Given this list of marker genes Arl4c, Ncoa2, Cxcl14, 1700072I22Rik, Vamp2, Igkv10-95, Frmd8, Chn1, Gm7969, Ccdc136, Emp1, Cyp2e1, Pex11a, Sult4a1 (sulfotransferase family 4A, member 1), AI504432 (NCBI Gene Id 99661), Fam110b, Laptm4b, Fbxw14 (NCBI Gene Id 99238), Pard6g, Prkce, Zxdb, Lrrtm4, Igdcc4, Itih5, Fam181b, Ftdc2, Def8, Smad7, Glb1l, Bcl2l11, Etv3, Ifih1, Ash1l, Pde4b, Zcchc7, Gm1965, Clps, Ccar1, Cpxm1, Baalc, Nsd3, Etv1, Syn2, Sv2a, Pdc, Msi2, Arhgap42, Jade1, Dnajb13, Foxb2, Kcnj6, Cers4 (NCBI Gene Id 67260), Gem, Wnt6, Ift81, Prkacb, Inppl1 (NCBI Gene Id 16332), Tspan6, Vps37a, Rbm28, Gnl1, Nkain3, Ifi44, Zmynd8, Tctn2, Pdf, Ctla2a, Vldlr, Egr1, Ptprk, Dusp5, Ntrk3, Slc25a30, Cyp2d22, S100a5, Nkx2-9, Col18a1, Esr1, Cpsf2, Zc2hc1a, Robo4, Lrrc49, Socs5, Mef2d, Misfa, Smarca2, Zbtb37 (NCBI Gene Id 240869), Klhl26, Plac8l1, Usp38, Nfkbia, Rbx1, Efna3, Gapdhs, Lpar4, Agxt, Arhgef28, Pck1, Rbbp6, Peak1, Palmd, Pygm, Myo10 (NCBI Gene Id 52514, myosin X), Nr4a1, Pkd2, Smc5, Prcd, Rps6ka3, Slc23a2, Emcn, Hyal1, Fundc2b, Zc3h12c, 1700001G11Rik, Hnrnpr, Cobll1, Jun, Rest, Sos1, Slit2, Cdip1, Polr2a, Marchf9, Fam168b, Cd164l2, Kcnk15, Nfatc2, Ptgr1, 1700108J01Rik, Trim61, Dydc1, Zbtb20, Ctnnal1, Tspan13, Mycbp2, Tcf25, Gata3, Slc41a1, Tbxa2r, Tgoln1, Slc35f1 (NCBI Gene Id 99729), Sema3d (sema domain, immunoglobulin domain (Ig), short basic domain, secreted, (semaphorin) 3D), Rasd1 (NCBI Gene Id 19416), Prkg1, Tcf4, Zdbf2, Camta1, Septin3, Scaf11, Nfkbie, Nrxn3, Siah2, Itga3, Hoxb2, Gatad2a, Paip1, 4930486L24Rik, Kif5a, Rilpl1, Iqgap2, Serpinb8, Ppp1r9a, Il36a, Sec14l3, Chrnb1, Wwc2, Nr4a2, Cdk14, Zrsr2, Dnmt3a, Lypd1, Mirlet7d, Arhgap32, Ddit4, Sema4c, Gm30230, Itga9, Usp34, Maff, Col4a1, Abcc12, Ccl19, Dnajc21, Ccdc185 (NCBI Gene Id 433386), Zfp40, Sash1, Chrna6, Srek1, Samd10, Trim9, Nfix, Pitpnc1, Tha1, Syt11, Slc16a5, Sgsm1, Skil, Nrxn1, Mex3a, Rfpl4b, Pglyrp2, Hook1, Eng, here is a description of the gene set: Mouse Gene Set: IVANOVA_HEMATOPOIESIS_STEM_CELL Mechanisms regulating self-renewal and cell fate decisions in mammalian stem cells are poorly understood. We determined global gene expression profiles for mouse and human hematopoietic stem cells and other stages of the hematopoietic hierarchy. Murine and human hematopoietic stem cells share a number of expressed gene products, which define key conserved regulatory pathways in this developmental system. Moreover, in the mouse, a portion of the genetic program of hematopoietic stem cells is shared with embryonic and neural stem cells. This overlapping set of gene products represents a molecular signature of stem cells. from publication Ivanova NB, Dimos JT, Schaniel C, Hackney JA, Moore KA, Lemischka IR (PMID 12228721) species: Mus musculus Genes in the expression cluster 'HSC Shared': up-regulated in hematopoietic stem cells (HSC) from adult bone marrow and fetal liver.